The following is a description of a gene set: from publication Sasaki H, Nishikata I, Shiraga T, Akamatsu E, Fukami T, Hidaka T, Kubuki Y, Okayama A, Hamada K, Okabe H, Murakami Y, Tsubouchi H, Morishita K (PMID 15471956) species: Homo sapiens Adult T-cell leukemia (ATL) caused by human T-cell leukemia virus type 1 (HTLV-1) infection, occurs in 2% to 4% of the HTLV-1 carriers with a long latent period, suggesting that additional alterations participate in the development of ATL. To characterize and identify novel markers of ATL, we examined the expression profiles of more than genes in 8 cases of acute-type ATL using microarray. One hundred ninety-two genes containing interleukin 2 (IL-2) receptor alpha were up-regulated more than 2-fold compared with CD4(+) and CD4(+)CD45RO(+) T cells, and tumor suppressor in lung cancer 1 (TSLC1), caveolin 1, and prostaglandin D2 synthase showed increased expression of more than 30-fold. TSLC1 is a cell adhesion molecule originally identified as a tumor suppressor in the lung but lacks its expression in normal or activated T cells. We confirmed ectopic expression of the TSLC1 in all acute-type ATL cells and in 7 of 10 ATL- or HTLV-1-infected T-cell lines. Introduction of TSLC1 into a human ATL cell line ED enhanced both self-aggregation and adhesion ability to vascular endothelial cells. These results suggested that the ectopic expression of TSLC1 could provide a novel marker for acute-type ATL and may participate in tissue invasion, a characteristic feature of the malignant ATL cells. Genes up-regulated in adult T-cell leukemia (ATL) cells compared to T lymphocytes from healthy controls. Human Gene Set: SASAKI_ADULT_T_CELL_LEUKEMIA, and this is the list of marker genes: ICMT, ENSG00000280071, RLN2, AIM2, ATP8A1, HDAC1, CD99, DYNLL1P3 (NCBI Gene Id 391012), IDH1, CHMP2A, MTX2, IRF4, ARL6IP5, TPX2, PLK1, MSC, FAS, WWTR1 (NCBI Gene Id 25937), SAP30, DHCR24, MSX1, SYT11, RECQL, UST, PAWR, SLC25A46, ACYP1, MKI67, FZD6, ADORA2BP1, POLR2E, TYMS, IFI16, UBE2C, POU4F1 (NCBI Gene Id 730659), MYL6B, BOLA2 (bolA family member 2), TP53TG1, CDKN3, PARP1 (NCBI Gene Id 142), ZWINT, GLB1, MED24, LPCAT4, SP1, RFC3, RASA1, TFCP2, MYB, GSTZ1 (NCBI Gene Id 2954), SELL, TFDP1, CETN3, NOMO1, BUB1B, DOK5, ANXA6, AP3S1, DYNLL1, PPP1CA, POLR2H, KIF11, ACOT8, PPP1CC, CNN2, PDE8B, NME1, JAK3 (NCBI Gene Id 3718), PSPHP1, NEDD4, TFRC (transferrin receptor), BARD1, PTPRM, HINT1, ARNT2, CD47, CDK13, PTTG1, TRIB2, MCM3, FHL2 (NCBI Gene Id 2274), TFAP2A, TOP2A, SSTR2, TUBB (tubulin beta class I), ZNF80, CCNA2, ATP2C1, PTHLH, CD3D, ETS1, PPIB, CCP110, LDLRAD4, GCHFR, SCCPDH, PMS1, HPGDS, NDUFAF1, BATF, VAMP5, IL2RA, RGS13, ARPC1B, TMED3, NMI, ATP5F1A, EXTL2, ACOT13 (acyl-CoA thioesterase 13), DLG3, KIF2C, PTPRN2, PRDX1, PCLAF, TRAFD1, PDCD10, LSM2, ISG20, MYCN, SMARCA2 (SWI/SNF related, matrix associated, actin dependent regulator of chromatin, subfamily a, member 2), ING1, FGFR1, PSMB2, PTPRJ, CCNB1, PARP3, ATP6V1A, DST, ISG15, ANXA2, CAV1, CEP164, UBA52, MYCBP, KIF14, MRPS12, TK1, PARM1, DLGAP5, STAT1, CORO1A, H4C3, FOXM1, PLD1, TRIB1, VBP1, CEBPA, GALK2, CCNB2, TRAPPC12, CENPF, RPA1, PCNA, MYO1D, KCNN4, PPID, HMGN4, ATP1B1, EMP1, CADM1, HMGB2, ETFA, SGCE, OAS2, RBBP4, PRDX4, DAAM1, ATP5MC3